Given this list of marker genes SLC17A5 (solute carrier family 17 member 5), TMEM106C, STRN3, TMEM183A, RALGAPB, CASP2, PAQR3, RSRP1, MXI1, USF2, SIDT2 (SID1 transmembrane family member 2), MAN1C1, SPATA6, PRRG1, ARFGAP3, GTF3C1, CTNS, WDR11 (NCBI Gene Id 79207), SMG6, COG4, BBS5 (Bardet-Biedl syndrome 5), CGGBP1, VPS35L, SHLD1, ANAPC15, CTDSPL2, USP21, CEP162, APLP2, AKT1S1, FGGY, FNIP2, PRKAB2, FBXL17, LRSAM1, RNLS, SIAE, SIN3A, COPG2, AKR1B10, ETV1, WDR62, FAHD1, H2AC18, PNKD, PIK3CG, IDUA, CCS, CTTNBP2NL, GHDC, MAGEE1, RHOQ, SFMBT1, CD99, PIKFYVE, TGFBR2, CDC42SE2, PDXDC1, FOXO3, TGIF1, NR1D2, AKR7A2, GLTP (NCBI Gene Id 51228), CD93, NUP62, BCAS3, SERHL2, EHMT2, SPAG9, PRPSAP2, CPT2, MAPK3, CHPF2, CHD9, KATNAL1, HMGCL, TM9SF1, FUCA1, QKI, SOS2, PEBP1, PLSCR4, USP9X, RAB11FIP5 (NCBI Gene Id 26056), ARHGAP24, PTOV1, DGUOK, ANKRD28, FAM219A, FMO5, RALGPS2, LMAN2, DDX42, PPP1R16A, AGO3, SLC16A7, RUFY3, FBXW4, CRYBG3, ARHGAP23, SCN3B, SPG11, CCPG1, RAB3GAP1, RSPH3, POLR2A, KLHL26, LDAF1, ASXL2, BMP2K, RNASET2, HTR2B, TSPAN31, PIP4K2C, SEC14L1, MTMR14, ZBED3, XPR1, EPRS1, FYCO1, DOCK4, DHX32, PINK1, PDZD8 (NCBI Gene Id 118987), LCMT1, H2AC25, NINJ1, SPTSSA, GPKOW, PPFIA4, SORBS3, MEAK7 (NCBI Gene Id 57707), MACO1, CTSB (cathepsin B), COMMD6, UBFD1, SELENOK, MKNK2, ABCC3, EZH1, CLN8, ZKSCAN5, KIZ, C3orf33, TRAK2, C8orf58, RNF180, SEPTIN10, EPB41L3, FRMD6, PIGQ, IL6R, CNOT4, CYP27A1, ARHGAP19, STOM, CIBAR1, ERMARD, MON2, GPR108, MGST1 (NCBI Gene Id 4257), RALGAPA2, FAT3, CD300A, XYLT2, C1QA, MBTPS1, TARS3, TRIM24 (NCBI Gene Id 8805), KCNK13, RBBP9, CCDC90B, COPS2, ABCC1, ABHD6, CROT, FNBP1, ORAI3, MAGED1, NNT, BAMBI, APPL2, ZSWIM9, TRPV2 (NCBI Gene Id 51393), MICAL1, AOAH, RAB5B, DMXL1, ATP13A2, PIK3R4, EEA1, TMX4, FOXRED2, SPA17, MYADM, PAQR7, CDKN1B, CAMSAP2, PIR, TMLHE, here is a description of the gene set: IL-10 or IL-6 stimulation of control 129xC57BL/6 murine bone marrow derived macrophages in the presence of LPS. We used microarrays to detail the global programme of gene expression changes in response to IL-6 or IL-10 stimulation in the presence of lipopolysaccharide. BMDMs were isolated from control, IL-6-/-, and IL-10-/- mice on a 129XBL/6 mixed background mice and differentiated in the presence of CSF-1 for 6-7 days. Cells were scraped and plated in 6 well plates at 2x10e6/well. Cells were washed with complete DMEM and rested for 1-2 hr before stimulation with combinations of IL-10 (10 ng/ml), IL-6 (2 ng/ml) or LPS (100 ng/ml) for 45 min or 180 mins. Complete biological replicates were performed. Genes up-regulated in bone marrow-derived macrophages with IL6 knockout and 45 min of stimulation by: LPS versus IL10 and LPS. studied in species Homo sapiens from publication El Kasmi KC, Holst J, Coffre M, Mielke L, de Pauw A, Lhocine N, Smith AM, Rutschman R, Kaushal D, Shen Y, Suda T, Donnelly RP, Myers MG Jr, Alexander W, Vignali DA, Watowich SS, Ernst M, Hilton DJ, Murray PJ (PMID 17114459) Human Gene Set: GSE5589_LPS_VS_LPS_AND_IL10_STIM_IL6_KO_MACROPHAGE_45MIN_UP